Given this list of marker genes Cdk7, Ppp2r1b (protein phosphatase 2, regulatory subunit A, beta), Lyn, E2f5, Cdkn1b, Ptk6 (PTK6 protein tyrosine kinase 6), Cul1, Tfdp1, Ppp2r2a (NCBI Gene Id 71978), Uba52, Ppp2ca, Skp2, Cdkn1a, Ccnd2, Mnat1, Rps27a, Uba52rt, Rbl1, Ubc, Ccnd3, Ubb, Rb1, Ccnh, Src, E2f2, Rbl2, Ppp2cb, Cdkn2b, Ppp2r1a, Skp1, Ccne2, Cdk6, Ccne1, Cks1b, Cdkn1c, E2f1 (E2F transcription factor 1), Ccnd1, Ppp2r3d, E2f4, Jak2, Cdk2, E2f3, Cdk4, Abl1, here is a description of the gene set: Cyclin D associated events in G1 Mouse Gene Set: REACTOME_CYCLIN_D_ASSOCIATED_EVENTS_IN_G1 species: Mus musculus